Given this list of marker genes GALE, TRAT1, B3GNT2, CCNA2, AXIN2, NGLY1, SEMA7A (NCBI Gene Id 8482), RAD18 (NCBI Gene Id 56852), ATP8A1, FSTL3, PPEF2, TECTA, AHI1, SIT1, FKBP5, MYL11, TMEM50B, DHX40 (DEAH-box helicase 40), ENDOU, FYB1, RGCC, AP3S1, CKM, MORC1, IL2RA, ART4, PTRH1, PRNP, AXL, MMP17, CD3G, PMEPA1, TUBB2A, PPT1, NEU3 (NCBI Gene Id 10825), SEC24B, TMEM120B, RAG1, TEDC1, CXCR4, LPXN, MCOLN2, RTKN2 (NCBI Gene Id 254060), CDC45, TUBB3, KIF18A, CASP6, PLXDC2, DAD1, ANGPTL2, ALDH1B1, PCLAF, IFNGR1 (NCBI Gene Id 3459), LAD1, GFI1, CDK2AP2 (NCBI Gene Id 10263), PLA2G12A, HMGCS2, SAPCD1, DGKE, PRELP, NHERF4, MTHFD2, CARHSP1, KIF4A, GRAP2, SLC35D1, ESM1, HPCAL1, CCND3, FBXL12, RDM1, CDH9, TCF12, SLAMF6, DPP4, GSR, BEST2, PITHD1 (NCBI Gene Id 96276), BHLHE40, MPP1, DDAH2, IL7R, PDLIM1, LAT, RASL10A, METTL8, DEGS2, SH2D1A, REXO2, PRRT1, CD28, TCOF1, MLX, HOGA1, TAS1R1 (taste 1 receptor member 1), CARD10, LCK, AKT2, ARHGAP9, ABHD8, SH2D2A, PTCRA, MLLT3, DDIT4L, MOV10L1, DGKA, WDR54, ARPP21, TMEM242, CTLA4, CD247, MS4A1, HAUS5, RHOH, ITK, GDPD1, LGALS9B, EDARADD, MED20, ENSA, IFT80, GPSM2, MTF2, EPCAM, HIBADH, NCK2, ITM2C, CNGA1, SEC24D, CENPM, BCL11B, TNFAIP8L1, EDEM1 (NCBI Gene Id 9695), COMP, RAB27A, PPARG, CDON, PLD4, SLAMF1, MC1R, PSMB8, GLYCTK (glycerate kinase), THY1, TMEM191C, DESI1, NCKAP1, IL17RB, CD3D, MS4A6A, BCL2, AGFG2, TK1, BST1, PDCD1, HSD11B1, MBNL3, PTPRF, MCUB, TPX2, ASF1B, MAOA, MGAT5, CPSF4L (NCBI Gene Id 651471), FBLN2, RPS6KL1, ENTPD5, ANXA2, NCAPH, GCOM1 (NCBI Gene Id 145781), INA, C1QTNF1, TEC, G6PC2, DTNBP1, CDC25B, SPIB, SLA2, PDRG1, TKTL1, PTH2R, KIFC1, CD3E, ANTKMT, ADA, ACOT8, DENND2D, MIF4GD, PRKCA, GSTT2, SOCS1 (NCBI Gene Id 8651), SYTL3, LIG1, IRAG2, TMEM134, BNIPL, MPZL2, POU2AF1, SEMA4A, here is a description of the gene set: from publication Belyaev NN, Biró J, Athanasakis D, Fernandez-Reyes D, Potocnik AJ (PMID 22581009) Human Gene Set: GSE24142_EARLY_THYMIC_PROGENITOR_VS_DN2_THYMOCYTE_DN Development of T-cells provides a unique opportunity to study cell-fate determination due to the accessability and the well defined stages of developmental stages. In order to understand the genetic programs underlying fetal and adult T‑cell fate specification we subjected highly purified fetal and adult T-cell progenitor populations to a genome‑wide transcriptional analysis. The aim was to identify molecular elements that govern T-cell fate specification as a whole but ultimately to isolate elements that were specific for a given population in a specific developmental window. Genes down-regulated in comparison of thymic progenitors versus DN2 thymocytes. species: Homo sapiens